Given this list of marker genes TNF, ACE, CYP24A1, CPN1, IL1A, RHOA, F12, BDKRB1, AGTR2, AGT, BDKRB2, KLK1, NOS3, AGTR1, PRKG1, ACE2, NOS1, ROCK1, REN, SERPINE1, KNG1, SERPING1, NPR1, KLKB1, NFKB1, MAPK1, CYP3A4, VDR, IL1B, here is a description of the gene set: RAS and bradykinin pathways in COVID-19 Human Gene Set: WP_RAS_AND_BRADYKININ_PATHWAYS_IN_COVID19 studied in species Homo sapiens